The following is a description of a gene set: Mouse Gene Set: GOBP_FORMALDEHYDE_METABOLIC_PROCESS The chemical reactions and pathways involving formaldehyde (methanal, H2C=O), a colorless liquid or gas with a pungent odor, commonly used as a fixative or an antibacterial agent. studied in species Mus musculus, and this is the list of marker genes: Adh5, Adh4, Esd, Kdm3a, Aldh3a2